The following is a description of a gene set: Abnormal erythrocyte physiology Any functional abnormality of erythrocytes (red-blood cells). Human Gene Set: HP_ABNORMAL_ERYTHROCYTE_PHYSIOLOGY studied in species Homo sapiens, and this is the list of marker genes: SPTA1 (spectrin alpha, erythrocytic 1), EPB41, EPB42, RHD, SLC4A1, RHCE, SPTB, PKLR, KCNN4, ANK1, RHAG, PIEZO1, SLC4A4, HBB, GYPC